The following is a description of a gene set: Genes predicted to be targets of miRBase v22 microRNA mmu_miR_6986_3p in miRDB v6.0 with MirTarget v4 prediction scores > 80 (high confidence targets). from publication Chen Y, Wang X (PMID 31504780) Mouse Gene Set: MIR_6986_3P species: Mus musculus, and this is the list of marker genes: Dhrs11, Irf2, Atxn7, Lpin1, Klhl31, Kcnd2, Rgs7bp, Actr2, Wdr37, Rrn3 (NCBI Gene Id 98048), Senp6, Pds5b, Celf2, Trim23, Zfp987, Ptger4, Herc3, Scn3a, Wnk1, Utp23, Steap2, Dner, Ank3, Slc18a2, Aak1, Cryzl1, Hoxa5, Erh, Ippk, Tmem86a, Ptpn3, Spopl, Herc6, Mdfic, Cdyl, Lmo7, Zfp654, Cog6, Ywhab, Mblac2, Cacnb4, Itch, Nppc, Cypt4, Plcxd2, B3galt2, Zfp867, Larp4 (NCBI Gene Id 52147), Naa15, Adam10, Pcdh17, Edil3, Tmem167, Micu3, Rbm44, Tsc22d2, Stam, Zbtb18, Sp4, Scai, Dsc2, Nup160, Hycc2, B3gnt8, Hmgb2, Hccs, Zfp763, Smarce1, Rab1a, Lifr, Cul1, Tab3, Strn4, Lrrtm2, Vstm5, Dkk2, Fbxo32, Pgap1, Map3k12, Txlng, Pou2f1, Cnrip1, Fgf12, Cdk13, Ankrd33, Cd46, Agmo, Chrna5, Rnf13 (ring finger protein 13), Crbn, Slc7a11, Fsbp, Zfp704, Prtg, Ugt2b38, Zfp655, Rbm27, Cyp2c70, Elapor2, Slc36a4, Unc13c, Cep97, Tmed5, Sox5, Napepld, Uox, Kansl1, Ccng2, H2az1, Astn1 (NCBI Gene Id 11899), Zfp942, Jph1, Magt1 (NCBI Gene Id 69751), Stx16, Gbp2b, Pgr (NCBI Gene Id 270116), Tead1, Sstr1, Nsd1, Zfp143, Slc5a8, Rab27b (RAB27B, member RAS oncogene family), Ccdc47, Cyp2j13, Ehf, Rlim, Dscaml1, Rbm39, Pbdc1, Col1a2, Runx1t1, Ing2, Flrt3 (NCBI Gene Id 77649), Mmp8, 9330159F19Rik, Barhl2, Fndc9, Tnp1, Ark2c, Spink10, Pabpc4l, Ptp4a1, Ttc23l, Enpep, Pot1a, Cd69, Ncoa7, Grb14, Cacng2, Slc19a2, Tbc1d4, Abhd18, Slitrk1, Tmem33, Tfam, Wsb1, Ctr9, Ccdc77, Kdm3b, Prkci, Cx3cr1 (NCBI Gene Id 13051), Prelid3b, Ikzf3, Tgfb2, Ahr, Gabra4, Usp6nl, Ces2b, Dock4, Aldh1a2, Pnn, Nova1, Scn9a, Pdgfa, Lyplal1, Zbtb44, Sh3kbp1, Abhd5, Ctnna2, Zfp729b, Thsd7a, Cdkn1b, Zfp367, Pakap (NCBI Gene Id 97198), Arid4b, Tmem106b, Aff2, Slc8a1, Slc9a2, Eomes, Cep135, Pclo, Hepacam2, Rxfp2, Sowahc, Nbeal1, Tmx1, Tm2d1, Usp10, Zfp653, Pawr, Cadm2, Acbd5, Grm5 (glutamate receptor, metabotropic 5), Fut9, Tshz1, Cpeb2, Xkr4, Wdr7, Mmp16, Fgd4, Spry2, Syt4, Morc4, Lonrf3, Osbpl8, Chd2, Zfp366, Rad18, Pparg, Edem3, Dnajc6, Tnrc18, Chit1, Smim15, Grik2, Apol7a, Smoc2, Slc9a6 (NCBI Gene Id 236794), Armc8, 2310030G06Rik, Cdk12, Scd2 (stearoyl-Coenzyme A desaturase 2), Hoxa10, Trpc5os, Kdm6a, Ccar2, Rictor, Tril, Ppp1r16b, Sucnr1, Ildr1, Atg2b, Copg2, Lcorl, Gdap1, Hs3st5, Palld, Maip1, Snx12, Mllt10, Fndc3a, Stxbp5, Ugt8a, Hcrtr2, Cdh7, Lrba, Fzd4, Ppp2r2b, Zfp715, Epc1, Nol4, Gnrhr, Ythdf3, Mob1b, Pja1, Nckap1, Rapgef4, Psmd14 (NCBI Gene Id 98839), Pdzd7, Dpp4, Rab33b, Neto1, Igf2bp3, Larp4b, Osbpl11 (NCBI Gene Id 224120), Dnm3, Trpc5, Robo2, Rab39b, Rwdd3, Sub1, Zfp850